Given this list of marker genes Mmp12, Epo, Gatad2a, Nr4a3, Rspo3, Mir216a, Ccl11, Lias, Mir145a, Ilk, Gbx2, Dchs1, Arhgap35, Psen1, Hoxa13, Hand1, Ext1, Grhl2, Gcnt4, Il10, Wnt7a, Ppp1ca, Runx1, Hif1a, Areg, Rxra, Clasp1 (NCBI Gene Id 76707), Nkx2-1, Tgif1, Hs2st1, Cited1, Nckap1, Aldh1a3, Ptk7, Kdm6a, Ift122, Plxna1, Nherf1, Gzf1, Agtr1b, Map3k1, Plet1, Klk1b1, Nrarp, Serpinb5, Hesx1, Smad4, Cc2d2a, Tsc1, Nfatc1 (nuclear factor of activated T cells, cytoplasmic, calcineurin dependent 1), Slc39a12, Mybpc3, Tbx19, Krt16, Nfatc4, Adarb1, Nkx2-5, Frzb, Crb3, Cxcl12, Sox8, Asb2, Pkd2, Spint2, Lama1, Ryr2, Jag2, Egfr, Cep290, Spint1, Sox9, Pdpn, Tgfb1, Six2, Tnni3, Dlx3, Msx1, Kdm6b, Sos1, Angpt1, Rbpj, Egln1, Ski, Kdr, Adam8, Stat5a, Tfap2c, Nup50, Pou5f1, Mesp1 (mesoderm posterior 1), Myh6, Krt17, Rala (v-ral simian leukemia viral oncogene A (ras related)), Rspo2, Acta1, Itgb3, Mylk, Slit2, Prkx, Igf1r, Epor, Gli2, Il6, Epha4, Map3k7, Mgp, Itga3, Tmeff2, Ctnnbip1, Smo, Sox2, Itgb5, Ube4b, Cplane2, Sdc4, Trp63, Dag1, Lama5, Krt28 (keratin 28), Osr1, Phb2, Dlg5, Sox10, Hoxd13, Ipmk, Wdr83, Epha2, Prkacb, Traf6, Gna13, Bmpr1a, Intu, Hdac5, Llgl2, Pkp2, Itgb1, Sec24b, Pgf, Hoxa5, Grem1, Kdm2a, Aldh1a2, Gcnt1, Gcm1, Greb1, Snai2, Apela, Aldh1a1, Ntn1, Fgf8, Rnf207, Ngfr, Nrg1, Ctns, Hhip, Msx2, Abl2, Ovol2, Stk3, Rock2 (NCBI Gene Id 77848), Krt6a, Stard13 (StAR related lipid transfer domain containing 13), Wnt5b, Hhex, Pla2g10, Pals1, Ctnnd1, Tgfb3, Htt, Tpm1, Hgf, Gorab, Alx1, Pthlh, Mthfr, Ext2, Taf10, Myh7, Wdr1, Nrp1, Heyl, Sfrp1, Mir143, Fkbp1a, Foxf1, Axin1, Mtss1, Hmga2, Lgr5, Casr, Zic2, Epb41l5, Myf5, Cav3, Col11a1, Tmem100, Matn1, Rps7, Ccdc39, Cfc1, Tbx2, Efnb2, Naglu, Tmtc3, Frs2 (NCBI Gene Id 327826), Itga2, Brd2, Phactr4, Gja1, Setdb2, Fgfr3, Wnt5a, Fmn1, Sox17, Tnf, Arhgap24 (Rho GTPase activating protein 24), Pitx2, Tnni1, Ntn4, Ahi1, Ddr1, Mycn, Alox12, Gata4, Cd151, Dsp (desmoplakin), Lgr4, Hoxa11 (homeobox A11), Mmrn2, Luzp1, Agtr2, Foxc1, Dlc1, Ripk4, Wnt2, Pard3, Pspn, Fgf7, Heg1, St14, Tmem67, Scnn1b, Clic4, Nos3, Enpp1, Prkaca, Wnt2b, Wls, Yap1, Bmpr2, Rdh10, Mdm4, Trim71, Timeless, Greb1l, Itga5, Pgr, Fzd3, Pafah1b1, Wt1, Artn, Rhob, Tead2, Maged1, Wnk4, Ccm2, Nodal, Igf1, Esr1, Ajuba, Abl1, Jag1, Lrp6, Shh, Tsc2, Wnt4, Foxd1, Krt12, Smad1 (NCBI Gene Id 17125), Mdk (NCBI Gene Id 17242), Plxnb2, Ahdc1 (NCBI Gene Id 320532), Myf6, Jhy, Kdm5b, Myc, Pax2, Csf1, Itga8, Dkk1, Klk14, Ccm2l, Irx1, Carmil2, Id4, Rreb1, Eya1, Csnk2b, Nfatc3, Smarca4, Txnrd1, Fat1, Btbd7, Hey2, Pdgfra, Slc12a2, Kif3a, Fuz, Notch1, Cyp7b1, Rhoa, Eng, Ift20, Lmo4, Fst, Gpc3, Coq7, Bmp10, Twsg1, Brsk2, Foxa2, Etv4, Bsg, Foxl1, Vasp, Gsdma3, Six4, Ift57, Dvl1, Efemp2, Pcdh8, Mks1, Kras, Tgfb2, Gdf7, Isl1, Tmem59l, Hoxb4, Ar, Dlg3, Gcnt3, Gata5, Npnt, Ret, S1pr1, Lcn2, Shox2, Flrt3, Glmn, Pdx1, Fgf3, Tbx1, Ift52, Agtr1a, Mef2c, Car9, Astn2, Cdh1, Hoxb13, Tcap, Ttn, Perp, Sufu, Plod3, Lzts2, Ptcd2, Car2, Septin4, Tgfbr3, Mdm2, Actg1, Foxe1, Wnt9b, Smad2, Sema3a, Lamc1, Gdnf, Cxcl10, Rbm15, Irx3 (NCBI Gene Id 16373), Dsc1, Crb2, Ttc8, Col3a1, Tbx3, Bmp7, Tbx4, Hoxb2, Nrp2, Kdm2b, Zdhhc7, Exoc5, Tulp3, Cluap1, Csmd1 (CUB and Sushi multiple domains 1), Tmed2 (transmembrane p24 trafficking protein 2), Hs3st3b1, Foxq1, Itgav (NCBI Gene Id 76358), Six1, Phldb2, Pdcd10, Sema4c, Gata3, Vdr, Ednra, Foxp1, Xirp2, Zfp568, Zic3, Mtor, Adamts12, Tfap2a, Ppp3r1, Nkx3-1, Edn1, Arhgap12, Vps52, Mib1, Hbegf, Tbx18, Zic5 (zinc finger protein of the cerebellum 5), Prickle1, Sall4, Krt27, Cdc42, Sall1 (spalt like transcription factor 1), Fzd6, Tctn1, Hes1, Tnnc1, Lrg1, Fat4, Bcl2, Specc1l, Cthrc1, Sirt6, Mesp2, Nr3c1, Shank3, Nphp1, Pou4f1, Src, Celsr1, Brsk1, Foxc2, Pdgfb, Nanog, Bbs4, Col4a1, Wnt3a, Irx2, Mst1, Hey1, Notch2, Krt71 (NCBI Gene Id 56735), Bmp5, BC028528, Zfpm1, Pten, Myl3, Ift172, Cd44, Fzd2, Wnt11, Armc5, Ctsd, Cecr2, Alms1, Stk4 (serine/threonine kinase 4), C2cd3, Met, Ophn1, Frem2, Ankrd1, Pofut2, Sh3bp1, Tacstd2, Rhoc, Nog, Adm, Pxn (paxillin), Clasp2, Grhl3, Flna, Setd2, Sostdc1, Vegfc, Pcdh15, Inhba, Myl2, Sox11 (NCBI Gene Id 67779), Bmp2, Lhx1, Dnaaf1 (NCBI Gene Id 68270), Hand2, Gpi1, Rgma, Actb, Arl13b, Trim28, Igfbp5 (NCBI Gene Id 98676), Mical2, Megf8, Tlx2, Actg2, Flg2, Ptch1, Dvl2, Hoxb7, Plxnd1, Tgfb1i1, Prkar1a, Tie1, Twist1, Rpgrip1l, Lhx2, Vegfa, Btrc, Aire, Fgf1, Vangl2, Tgfbr2, Tal1, Esrp1, Wnt10a (wingless-type MMTV integration site family, member 10A), Pkhd1, Apaf1, Commd5, Kdf1, Sulf1, Noto, Ajap1, Wnt7b, Scnn1g, Hs3st3a1, Tnnt2, Med12 (NCBI Gene Id 59024), Flt1, Pak1, Socs3, Sema3c, Lrp5, T, Ccdc103, Spry2, Hoxd11, Cxcr4, Dll1, Ccn1, Sfrp5, Pax3, Msgn1, Fgfr1, Ahr, Tek, Erbb4, Pfn1, Kif20b, Fkbpl, Shroom3, Mthfd1, Sapcd2, Acta2, Vcl, Stox1, Epha7, Lbx1, Fzd5, Ly6e (NCBI Gene Id 17069), Ctnnb1, Lif, Gli3, Runx3, Fermt2, Mir217, Lin7c, Hes5, Sfrp2, Wnt1, Tgfbr1, Dicer1, Nphp3, Tead1, Macf1, Folr1, Hectd1, Six3, Dspp, Kat2a, Mmp14, Lrp2, Foxa1, Deaf1, Opa1, Cobl, Foxh1, Chrd, Aplnr, Prox1, Crygs, Exoc4, Tbx6, Traf3ip1, Bcl10, Casp8, Wnt6, Pax7, Ctsz, Rab10, Ncoa3, Brpf1, Dll4, Esrp2, Krt25, Adamts5, Nf2, Fermt1, Rasip1, Srf, Atp7a, Klf4, Cdk20, Med1, Tor1a, Casp3, Robo2, Dlg1, Bmp4, Chuk, Etv5, Adamts16, Tbx20, Lef1, Fgf2, Spry1, Fras1, Krt6b, Arid1a, Tbx5, Robo1, Pkd1, Mir216b, Spag6l, Grsf1, Smarca1 (NCBI Gene Id 93761), Mthfd1l (NCBI Gene Id 77586), Col5a1, Wnt3, Chd7, Sema3e, Etv2, Wdpcp, Rarg, Snai1, Acvr1, Actc1, Podxl, Cfl1, Zfpm2, Esr2, Tnc, Stc1, Mylk2, Itgb4, Hnf1a, Itgax, Cited2, Scrib, Fem1b, Zeb2, Mrtfa, Cxcr2, Fzd1, Myo9a, Rara, Fgfr2, Klhl3 (kelch-like 3), Foxn4, Fgf10, Pbx1, Ccdc40, Smad7, Pdgfa, Enah (NCBI Gene Id 98642), Camsap3, Syne4, Msn, Mmp2, Foxf2, Gdf2, Ihh, Stat1, Tmem79, Rab23, Pml, Tcf15, Tcf7l1, Scx (scleraxis scleraxis bHLH transcription factor), Lbx2, Tgm2, Nkd1, Ecsit, Egf, Ctsh, Stil, Acvrl1 (activin A receptor, type II-like 1), Tcf21, Agt, Foxn1, Sema5a, Hnf1b, Notch4, Pax8, Pik3cd, Smad3, Cplane1, Grb2, Ctsl, Ceacam1, Eomes, Kif26b (kinesin family member 26B), here is a description of the gene set: Mouse Gene Set: GOBP_TISSUE_MORPHOGENESIS The process in which the anatomical structures of a tissue are generated and organized. studied in species Mus musculus